Given this list of marker genes KCNAB2, SPEN, FOXF1, RFX6, RECQL4, LUZP1, TELO2, FANCD2, STRA6, HSPG2, MYCN, PDPN, SETBP1, MMP23B, ASXL1, RARB, WNT7B, SIK3, RERE, FLI1, UBE4B, PRDM16, PRKCZ, SKI, CASZ1, GABRD, here is a description of the gene set: species: Homo sapiens Annular pancreas A congenital anomaly in which the pancreas completely (or sometimes incompletely) encircles the second portion of duodenum and occasionally obstructs the more proximal duodenum. Human Gene Set: HP_ANNULAR_PANCREAS